Given this list of marker genes CUL1, PSMB5, PSMC4, PSMB1, PSMD1, UBA52, FBXL18 (NCBI Gene Id 80028), SKP1, ADRM1, PSMD11, PSMA1, PSMC1, PSMD14, PSMD6, SEM1, PSMD2, PSMC5, PSMC3, PSMA6, PSMB6, PSMC6 (proteasome 26S subunit, ATPase 6), PSMD12, PSMD13, PSMB7, PSMA4, PSMA5, PSMB2, FBXL7, PSMA7, PSMD7, PSMB3, RPS27A (NCBI Gene Id 6233), PSMD3, PSMB4, PSMC2, AURKA, UBB, UBC, PSMA2, RBX1 (ring-box 1), PSMA3, PSMD8, here is a description of the gene set: part of: G2/M Transition The protein levels of aurora kinase A (AURKA) during mitotic entry and in early mitosis can be reduced by the action of the SCF-FBXL7 E3 ubiquitin ligase complex consisting of SKP1, CUL1, RBX1 and FBXL7 subunits. FBXL7 is the substrate recognition subunit of the SCF-FBXL7 complex that associates with the centrosome-bound AURKA, promoting its ubiquitination and proteasome-mediated degradation. Overexpression of FBXL7 results in G2/M cell cycle arrest and apoptosis.<p>FBXL7 protein levels are down-regulated by the action of the SCF-FBXL18 E3 ubiquitin ligase complex, consisting of SKP1, CUL1, RBX1 and the substrate recognition subunit FBXL18. FBXL18 binds to the FQ motif of FBXL7, targeting it for ubiquitination and proteasome-mediated degradation, counteracting its pro-apoptotic activity. Cell cycle stage-dependency of down-regulation of FBXL7 by FBXL18 is unknown. Reactome Pathway: FBXL7 down-regulates AURKA during mitotic entry and in early mitosis species: Homo sapiens